The following is a description of a gene set: species: Homo sapiens The ability of dendritic cells (DCs) to activate immunity is linked to their maturation status. In prior studies we have shown that selective antibody-mediated blockade of inhibitory FcgRIIB receptor on human DCs in the presence of activating immunoglobulin (Ig) ligands leads to DC maturation and enhanced immunity to antibody-coated tumor cells. Here we show that Fcg receptor (FcgR) mediated activation of human monocytes and monocyte-derived DCs is associated with a distinct gene expression pattern, including several inflammation associated chemokines as well as type 1 interferon (IFN) response genes including the activation of signal transducer and activator of transcription 1 (STAT1). Human Gene Set: GSE7509_UNSTIM_VS_FCGRIIB_STIM_MONOCYTE_DN from publication Dhodapkar KM, Banerjee D, Connolly J, Kukreja A, Matayeva E, Veri MC, Ravetch JV, Steinman RM, Dhodapkar MV (PMID 17502666) Genes down-regulated in monocytes: untreated versus anti- FcgRIIB., and this is the list of marker genes: POLG, ARV1, SORBS3, DDX42, RBM4, ZBTB37, CPEB1, TRAK1, LUC7L2, FRY, CCDC77, MEIS2, PAXIP1, CCDC141, GPHN, MICAL3, SRGAP2, FSTL4, REXO4, NFAT5, DYNC1LI2, AP3D1, IKBKB, ANXA9, PLA2R1, MIR340, ZDHHC1, CRTC2, NAV1, MTX3, ITPR1, PTPRD, DCLK2, ARID4A, MACF1, MAP3K4, PHC3, ELK4, PRPF38B, IFT140, RBM28, KDM3A, TMEM119, TAF1A, BRWD3, TTLL4, ACACB, CEP135, MIR99A, STX3, EPS15L1, ARAF, TAFAZZIN, CDC42BPA, NUP210, EDC4, NXF1, TRUB2, AASDH (NCBI Gene Id 132949), GOLGA1, OSBPL7, TCF25, R3HDM1, PARP8, PPP6R2 (protein phosphatase 6 regulatory subunit 2), CLK2, ZFYVE16, MIR211, ITGA9, SLC4A8, NDOR1, FHIP2A, PACRGL, PRDM2, CCNT2, RUFY2, NCAPD2, HMCN1, RAF1, VWA3B, PANK4, C2CD3, TNRC6A, VARS2, CLEC2D, PMS2, PAN2, DEPDC5, PLA2G6, SCAPER, ASXL2, SMTN, SCARNA17, MTF2, CCNL2, PPOX (NCBI Gene Id 7440), SH3PXD2A, SNRNP70, CHD9, N4BP2L2, MCOLN1, SNAPC4, TET2, OGT, IFFO1, BCKDHB, FBRS, KLC1, ATP8A1, PDE4A, DMTF1, ALS2CL, FCHO2, NBEA, SNORD73B (NCBI Gene Id 114655), ARID4B, AFG2B, GTF2IRD1, CABIN1, INO80D, LRRFIP1, SNHG1, BICD2, TROAP, HPS1, PHLDB1, IFT80, CARS2, STXBP5, MIR301B, HELQ, IVNS1ABP, NFRKB, APPL2, BAZ2A, TCIRG1, MBD6, FMN1, CLMN, PBX3, SON, TNRC6C, ARHGAP12, CCL20, WNK1, XIST, NAV2, AFG1L, TIAM1, TUBGCP3, VWF, NCOR1, DISP1, ZER1, SGIP1, CNTRL, HAP1, ATP9B, ZC3H7A, PRDM10, RORA, RSAD1, AGO2, BRPF3, TEAD1, BOD1L1